The following is a description of a gene set: species: Homo sapiens Human Gene Set: GOBP_INHIBITORY_SYNAPSE_ASSEMBLY The aggregation, arrangement and bonding together of a set of components to form an inhibitory synapse., and this is the list of marker genes: CBLN1, CLSTN3, CLSTN2, SEMA4D, GABRA5, GABRA2, LHFPL4, HAPLN4, GABRG3, MDGA1, GABRB3, PLXNB1, SEMA4A, FGF13, GABRA4, NLGN2, NPAS4, GABRA1, GABRG2, SRGAP2, SRGAP2C, WNT5A, GABRA3, CBLN4, GABRG1, GABRB2, LGI2, GABRE, GABRA6